Given this list of marker genes REEP5 (NCBI Gene Id 94845), INPP5J, ARMT1, ABCG1, LONP2, AGGF1, FAM174B, RETREG1, EEF1A2 (eukaryotic translation elongation factor 1 alpha 2), SLC39A6, TSPAN1, PTP4A2, ACOT2, TMBIM6, GNB1, DNALI1 (dynein axonemal light intermediate chain 1), SKP1, CRIP1, CELSR1, ELOVL5, DALRD3, FOXA1, TSPAN13, MYO5C, COX6C, BLVRA, here is a description of the gene set: About 70-80% of breast cancers express estrogen receptor alpha (ER-alpha), and estrogens play important roles in the development and growth of hormone-dependent tumors. Together with lymph node metastasis, tumor size, and histological grade, ER status is considered as one of the prognostic factors in breast cancer, and an indicator for hormonal treatment. To investigate genes and pathways that are associated with ER status and epithelial cells in breast tumor, we applied laser capture microdissection (LCM) technology to capture epithelial tumor cells from 28 lymph node-negative breast tumor samples, in which 17 patients had ER-alpha+ tumors, and 11 patients have ER-alpha- tumors. Gene expression profiles were analysed on Affymetrix Hu133A GeneChip. Meanwhile, gene profiles using total RNA isolated from bulk tumors of the same 28 patients were also generated. In total, genes and genes with significant P-value and having significant differential expression between ER-alpha+ and ER-alpha- tumors were identified from the LCM data set and bulk tissue data set, respectively. A total of genes were found to be common in both data sets, while genes were unique to the LCM data set and genes were present only in the bulk tumor data set. Pathway analysis with the genes using Gene Ontology suggested that genes involved in endocytosis, ceramide generation, Ras/ERK/Ark cascade, and JAT-STAT pathways may play roles related to ER. The gene profiling with LCM-captured tumor cells provides a unique approach to study epithelial tumor cells and to gain an insight into signaling pathways associated with ER. from publication Yang F, Foekens JA, Yu J, Sieuwerts AM, Timmermans M, Klijn JG, Atkins D, Wang Y, Jiang Y (PMID 16261164) Genes up-regulated in bulk samples from early primary breast tumors expressing ESR1 vs the ESR1 negative samples. studied in species Homo sapiens Human Gene Set: YANG_BREAST_CANCER_ESR1_BULK_UP